The following is a description of a gene set: Human Gene Set: GAVISH_3CA_MALIGNANT_METAPROGRAM_24_CILIA In this study, an extensive analysis was conducted to define meta-programs (MPs) capturing intra-tumor heterogeneity across a spectrum of tumor types. The approach utilized non-negative matrix factorization (NMF) to analyze each cell type separately within individual tumor samples. This involved the analysis of malignant cells, macrophages, fibroblasts, endothelial cells, epithelial cells, T-cells, and B-cells. NMF was executed with varying parameter values (K=4, 5, 6, 7, 8, 9), thereby generating 39 programs for each cell type per sample. Each NMF program was summarized by the top genes based on NMF coefficients.\nRobust MPs were then delineated for each cell type using a set of stringent criteria, including recurrence within the same tumor, similarity to programs in other tumors, and non-redundancy within a tumor. Subsequently, these robust NMF programs were clustered (per cell type) based on Jaccard similarity, leading to the identification of MPs associated with each cell type.\nTo enhance the quality of the MPs, a refinement steps were undertaken, involving the removal of MPs suspected of reflecting low-quality data (with an overrepresentation of ribosomal proteins or mitochondrial-encoded genes), single-study inclusion, or similarity to miss-annotated cell types. Genes upregulated in subsets of cells of a given type within various tumors species: Homo sapiens from publication Gavish A, Tyler M, Greenwald AC, Hoefflin R, Simkin D, Tschernichovsky R, Galili Darnell N, Somech E, Barbolin C, Antman T, Kovarsky D, Barrett T, Gonzalez Castro LN, Halder D, Chanoch-Myers R, Laffy J, Mints M, Wider A, Tal R, Spitzer A, Hara T, Raitses-Gurevich M, Stossel C, Golan T, Tirosh A, Suvà ML, Puram SV, Tirosh I (PMID 37258682), and this is the list of marker genes: DYNLRB2, DNAAF1, DNAH5, MORN2, SPA17 (NCBI Gene Id 90953), MRPS31, CES1, ZMYND10, DNALI1, PSENEN, C12orf75, SLC44A4, IQCG, CIMIP1, FABP6, FOXJ1, DPCD, OSCP1, TUBA1A, IGFBP2, TSPAN1, WDR54, CIMAP3, RSPH1, HOATZ, CIMAP1B, CFAP90, CAPS, MS4A8, DYNLT2B, IGFBP7, KIF9, TPPP3, NUCB2, SPMIP6 (NCBI Gene Id 84688), CETN2, CRIP1, LRRIQ1, PIERCE1 (piercer of microtubule wall 1), CFAP276, PLAC8, MLF1, CFAP144, GSTA1, IFT57, LRRC23 (leucine rich repeat containing 23), EFHC1, CAPSL, FAM229B